Given this list of marker genes FLVCR1, SLC22A17, ASIC3, ABCB6, PGRMC2, ABCC5, ABCB7, HPX, SLC48A1, LCN2, FLVCR2, SLC46A1, here is a description of the gene set: The directed movement of an iron coordination entity into, out of or within a cell, or between cells, by means of some agent such as a transporter or pore. studied in species Homo sapiens Human Gene Set: GOBP_IRON_COORDINATION_ENTITY_TRANSPORT